Given this list of marker genes HPCAL1, H2AC25 (H2A clustered histone 25), C1orf21, WIF1, SARS1, BMP8B, H4C3 (NCBI Gene Id 8364), CTNNAL1, SELENOP, GSTP1, MALAT1, OCIAD2, LINC00662, MYL6, MEPE, VAMP2, CAMTA1, CDC42EP3, SERPINE2, MEF2C, PDGFA, ORAI3, SNX4, AK2, SLPI, IBSP, CD300A, NCAM1, CLIC3, H1-2, ADIRF, PDGFD, NAPA, STEAP4, IRX5, TCEA3 (NCBI Gene Id 6920), DPCD, CARHSP1, ACTG1, CADM1, EPDR1, HSBP1L1, SNRPN, LOXL4, CD200 (NCBI Gene Id 4345), EMP2, GBE1, NUDT1, INHBA, CSNK2B, CD55, PARK7, UNC5B-AS1, SNHG8, PLP2 (proteolipid protein 2), SOST, SLK, MTFP1, SMDT1, CD44, SFT2D1, C1orf43, CLEC11A, BEND5, GSN, UNC5B, DOK5, DDIT4, TMEM106C, AKAP9, STC2, CLK3, MEF2A, LITAF, SNHG7, LIMCH1, COPZ1, SLX9, CDH15, CNBP, TF, DHPS, STEAP3, RNF7, RNMT, SERBP1, TP53I11, SERPINI1, FABP3, EIF3I, CIAO2B, DDX18, BMP2, ATP2B1, FAM20C (FAM20C golgi associated secretory pathway kinase), FOLR1, RNF5, INTU, IFITM5, TPI1, ANP32B, SGCG, BHLHE40, DDIT4L (DNA damage inducible transcript 4 like), POLR2I, PLS3, STK17A, POLR1D, PRDX2, EGLN3, C1orf198, CDK18, PKIG, F13A1, GPI, MAD1L1, DAP, H1-0, NINJ1, NDUFB4, EPB41L4A-AS1, MCRIP2, RHBDL2, IRX3, SLC16A8, HADH, TMEM256, YTHDC1, ZNF292, JAM2, BST2, ALPL, LIFR, ALDOA, MAP2K1, DPYSL3 (NCBI Gene Id 54406), NDNF, CTSC, PLAAT3, CPEB4, ACTN4, RAMP1, TAF1D, SERPINB1, HDAC5, RGS10, ITGB2, S100A13, ALDOC, COL10A1, EIF3H, APPL1, RNF181, DBI, MXI1, CIMIP2B (NCBI Gene Id 731600), DAPK2, TGFA, COX6A2, WDR54, RASSF7, CHAD, CENPX, GNG5, RIPOR2, IRX6, CITED2, DEPP1, CHMP4C, GPX3 (glutathione peroxidase 3), RPS19BP1, BMP4, PGAM1, SLC16A3, CLIC1, SNAPC1, STN1, PHOSPHO1, PTGDS, ATP5MC2, CNFN, NR1D1, LRRC28, COL22A1 (NCBI Gene Id 256626), ENPP2, ANKRD12, here is a description of the gene set: The transformation of benign lesions to malignant tumours is a crucial aspect of understanding chondrosarcomas, which are malignant cartilage tumours that could develop from benign chondroid lesions. However, the process of malignant transformation for chondroid lesions remains poorly understood, and no reliable markers are available to aid clinical decision-making. To address this issue, we conducted a study analysing 11 primary cartilage tumours and controls using single-cell RNA sequencing. By creating a single-cell atlas, we were able to identify the role of endoplasmic reticulum (ER) stress in the malignant transformation of conventional central chondrosarcomas (CCCS). Our research revealed that lower levels of ER stress promote chondrosarcoma growth in a patient-derived xenograft mouse model, while intensive ER stress reduces primary chondrosarcoma cell viability. Furthermore, we discovered that the NF-?B pathway alleviates ER stress-induced apoptosis during chondrosarcoma progression. Our single-cell signatures and large public data support the use of key ER stress regulators, such as DNA Damage Inducible Transcript 3 (DDIT3; also known as CHOP), as malignant markers for overall patient survival. Ultimately, our study highlights the significant role that ER stress plays in the malignant transformation of cartilaginous tumours and provides a valuable resource for future diagnostic markers and therapeutic strategies. Almost exclusively present in Med samples. It was characterized by co-expression of hypertrophic chondrocyte markers COL10A1/Collagen X, COL1A1/Collagen I, and bone mineralisation genes IBSP and IFITM5. from publication Su Z, Ho JWK, Yau RCH, Lam YL, Shek TWH, Yeung MCF, Chen H, Oreffo ROC, Cheah KSE, Cheung KSC (PMID 38267611) Human Gene Set: SU_HO_CONV_CENT_CHONDROSARCOMA_STROMAL_C0_MINERALISATION_STROMAL_CELL studied in species Homo sapiens